Given this list of marker genes Slc20a2, Slc17a1, here is a description of the gene set: electronically inferred by orthology from the curated human pathway This event has been computationally inferred from an event that has been demonstrated in another species.<p>The inference is based on the homology mapping from PANTHER. Briefly, reactions for which all involved PhysicalEntities (in input, output and catalyst) have a mapped orthologue/paralogue (for complexes at least 75% of components must have a mapping) are inferred to the other species. part of: SLC-mediated transport of inorganic anions Reactome Pathway: Sodium-coupled phosphate cotransporters species: Mus musculus